The following is a description of a gene set: species: Mus musculus Mouse Gene Set: REACTOME_DEGRADATION_OF_CYSTEINE_AND_HOMOCYSTEINE Degradation of cysteine and homocysteine, and this is the list of marker genes: Tst, Cth, Gadl1, Sqor, Txn2, Suox, Cdo1, Fmo1, Slc25a10, Tstd1, Mpst, Ethe1, Ado